Given this list of marker genes HSPD1, DDO, ACOX2, ATP5F1A, TIMM50, CHCHD4, GRPEL1, UBC (NCBI Gene Id 7316), MTX2, RPS27A, AGPS, CAT, ACOT4, ATP5MC1, CYC1, FXN, TOMM7, CMC2 (NCBI Gene Id 56942), GFER, VDAC1, PEX13, PEX16, GRPEL2, PEX19, SLC25A13, IDH1, CHCHD10, TYSND1, AGXT, ATAD1, ACOT8, PEX26, PEX12, ALDH3A2, HSD17B4, SGTA, TIMM10, UBE2D2, CS, OTC, LDHD, SEC61B, BAAT, ATP5F1B, STX1A, CMC4, DHRS4, STX5, COA6, UBE2D3, COA4, GNPAT, UBB, GET4, ACAA1, PRNP, MLYCD, DECR2, EPHX2, TOMM6, UBA52, UBE2D1, HSCB, NUDT7, SLC25A4, ACOX3, BCS1L, USP9X, TAFAZZIN, HAO1, CROT, PECR, LONP2, TIMM17B, NOS2, PAOX, CHCHD5 (coiled-coil-helix-coiled-coil-helix domain containing 5), HMOX1, TIMM10B, TOMM70, SAMM50, COX19, DNAJC19, VAPA, PXMP2, PEX7, TIMM22, CAMLG, TIMM21, GET3, HACL1, ABCD3, AMACR, OTOF, TIMM23, ECI2, NUDT19, ACO2, SEC61G, CRAT, ACBD5, PAM16, FIS1, PEX2, TOMM22, TIMM44, PXMP4, COQ2, ABCD1, TOMM20, TIMM9, SLC25A12 (solute carrier family 25 member 12), HMGCL, SLC25A17, PEX3, PIPOX, PEX5, GSTK1, VAMP2, ACOX1, GDAP1, PEX11B, ZFAND6, UBE2J2, PITRM1, TIMM17A, EHHADH (NCBI Gene Id 1962), TIMM13, IDE (NCBI Gene Id 3416), TIMM8B, MPV17, CHCHD2, TOMM40, SLC25A6, APP, ABCD2, BAG6, PEX14, EMD, CYB5A, SERP1, PEX10, IDH3G, ACOT2, HAO2, SLC27A2, SCP2, PMPCB, PEX1 (NCBI Gene Id 7788), HSPA9, ECH1, PMPCA, CHCHD7, MTX1, UBL4A, PHYH, TOMM5, NDUFB8, DAO, COX17, CHCHD3, GET1, PEX6, TIMM8A (translocase of inner mitochondrial membrane 8A), here is a description of the gene set: Protein localization encompasses the processes that establish and maintain proteins at specific locations. Mechanisms that target proteins to particular locations in the cell typically involve a motif in the targeted protein that interacts with proteins located at the destination.<br>Mitochondrial proteins encoded in the nucleus may be targeted to the outer membrane, intermembrane space, inner membrane, or the matrix. A presequence or an internal targeting sequence causes a protein in the cytosol to interact with the TOMM40:TOMM70 complex in the outer mitochondrial membrane. After passage across the outer membrane, sequence motifs cause proteins to be targeted to the outer membrane via the SAMM50 complex, to the inner membrane via the TIMM22 or TIMM23 complexes, to the matrix via the TIMM23 complex, or proteins may fold and remain in the intermembrane space.<br>All of the proteins contained in the peroxisomal matrix are imported from the cytosol by a unique mechanism that does not require the imported proteins to be unfolded as they cross the membrane. In the cytosol, receptor proteins, PEX5 and PEX7, bind to specific sequence motifs in cargo proteins and then interact with a protein complex containing PEX13, PEX14, PEX2, PEX10, and PEX12 in the peroxisome membrane. The cargo proteins then pass through a proteinaceous channel in the membrane and PEX5 is recycled by a mechanism involving ubiquitination and deubiquitination.<br>Most peroxisomal membrane proteins (PMPs) are inserted into the peroxisomal membrane by the receptor-chaperone PEX19 and the docking receptor PEX3. PEX19 binds the PMP as it is translated in the cytosol. The PEX19:PMP complex then interacts with PEX3 located in the peroxisomal membrane. Through a mechanism that is not yet clear, the PMP is inserted into the peroxisomal membrane and PEX19 dissociates from PEX3. Reactome Pathway: Protein localization studied in species Homo sapiens